Given this list of marker genes Il4, Oas1f, Defb25, Postn, Ifng, Ticam2, Oas1h, Il18, P2ry2, Lpl, Ripk2, Hc, Wnt5a, Nod2, F2rl1, Trim32, Tlr3, Selenok, Tlr4, Ffar3, Mif, Il1b, Oas1g, Card9, Clec7a, Tgfb1, Chia1 (NCBI Gene Id 81600), Tlr9, Havcr2, Trpv4, Il17f, Il4ra, Adcyap1, Il17a, Tirap, Twist1, Il6, Oas1e, Il16, Aif1, Il7, Tslp, Oas1b, Cd74, Ager, Tnfsf4, Egr1, Adam17, Adipoq, Mbp (myelin basic protein), Lgals9, Il33, Pycard, Csf1r, Oas1c, Adora2b, Ffar2, Chil4, Eif2ak2, Syk (spleen tyrosine kinase), Oas3, Cd84, Lbp, Tnf, Ccl5, Chil5, Aire, Oas1a, App, Myd88, Chil3, Il17ra, Alox8, Tlr2, Mapk9, Chil6, Ccn1, Mavs, Ticam1, Mcoln2, Hmgb1, Lrp1, Tlr7, Il1rl1, Il6ra, Oas1d, here is a description of the gene set: studied in species Mus musculus Mouse Gene Set: GOBP_POSITIVE_REGULATION_OF_CHEMOKINE_PRODUCTION Any process that activates or increases the frequency, rate, or extent of chemokine production.